The following is a description of a gene set: Mouse Gene Set: GOBP_IMMUNOLOGICAL_MEMORY_PROCESS Any process of the immune system that can contribute to the formation of immunological memory or an immune response based upon activation of immunological memory. species: Mus musculus, and this is the list of marker genes: Ighe, Cd70, Cd81, Ebag9, Tnfrsf14, Cd46, Cd160, Il23a, Pck1, Bcl6, Tsc1, Tnfsf4, Fgl2, Cd27, St3gal1, Itgb6, Itgb8, H2-Ea